The following is a description of a gene set: studied in species Homo sapiens Human Gene Set: HP_ABNORMAL_RETINAL_NERVE_FIBER_LAYER_MORPHOLOGY Abnormal retinal nerve fiber layer morphology A structural abnormality of the retinal nerve fiber layer, and this is the list of marker genes: DNAJC30, MT-CO3, MT-CO1, MT-ATP6, PDGFRB, MT-CYB (mitochondrially encoded cytochrome b), MT-ND6, SACS (sacsin molecular chaperone), FAS, NDUFS2, OPA1, MT-ND4L, MT-ND2, CYP27A1, PTPN22, MT-ND1, MT-ND5, MT-ND4